Given this list of marker genes SGF29, HLX, FN1, RAB13, LAMP3, SPSB3, CD48, PACS1, NAIP, CTSZ, CTNNA1, CDKN1A, IL6R, RTN1, DDIT3, ARHGAP12, CD84, ZNF665, CTSB, IGSF6, TRAPPC6A, SYNE1, RPS27, DHRS12, RGL1 (NCBI Gene Id 23179), GRN, CTSS, SMARCD3, PLXND1, DAAM2, C1S (complement C1s), DDX60 (DExD/H-box helicase 60), PLEK, PELI2 (pellino E3 ubiquitin protein ligase family member 2), LY9, SYNGR2, MCM3AP-AS1, KLC1, HLA-F, RNF130, PIK3C2A, IFI30, TBXAS1, CLEC7A, SCML1, MARCKS, CACNB1, PECAM1, DACT1 (NCBI Gene Id 51339), ACP5, ARAP2, CROCCP2, SYNJ2BP, ZSWIM8, SGPL1, ARAP1, BCL6, FCGRT, CD68, NPC2, CD83, BTN3A1, SLC35E2A, CSF2RA, THBS2, REPIN1, OCM2, YPEL5, KAT8, FPR3 (NCBI Gene Id 2359), FCGR2B, MXI1, OFD1, DPYD, ZNF573, LIPA, HLA-C, HLA-E, SLC7A7, CCL2, BCL11B, ST3GAL5, FAM168A, N4BP2L2, IL4R, COQ8A (NCBI Gene Id 56997), FAM193B, LY75, TSC22D1, FIG4, HERC1, CD209, LRP10, TSPAN4, C1orf54, IL3RA, LIMCH1, RYK, ATP6AP1, CYBB (NCBI Gene Id 1536), GP1BA, SLC1A3, CTSA, CD302, GABARAP, SIRPA, CD81, CREG1, NEU1, ARRB1, MS4A6A, SLC8B1, ZNF266, VAMP3, TBC1D1, IFNGR2, MARCHF8, DMXL2, RHOQ, SRSF5, ABCA5, CYTH4, SLC11A2, VPS11, TSC22D3, IPCEF1, RAB20, TLR1, ZMIZ2, MINDY1, PLXNB2, POU2F1, NAGLU, CCL22, PDGFC, LYN, CKAP4, TMT1A, FSCN1, BASP1, TIMP2, TYROBP, PINK1, CCR1, R3HDM2, TGFBI, LBH, PLEKHA1, SQSTM1, FTL, ALDOAP2, ACP2, TNKS, ATP8A2, BACH2, GFOD3P, VNN2, CD86, IL1R2, MX2, CTSO, KLHL3, S100A8, MGAT1, ST14, TSPAN6, SLC2A6 (solute carrier family 2 member 6), FCER1G, TMEM176A, TYMP, PTPRE, TNFSF13, NCF1C, MILR1, CSF1R, SIGLEC5, CXCR4, SALL2, RIPK2, PLOD3, ENG, HCK, TXNIP, SLC31A2, LDLRAP1, LMBR1L, CRYL1, ZNF329, CBX6, PIP5K1C, LGALS3, PTGS1, WDR19, HLA-DPB1, KMO, ZSCAN18, MTERF4, ZNF629, here is a description of the gene set: Human Gene Set: GSE24634_TREG_VS_TCONV_POST_DAY5_IL4_CONVERSION_DN from publication Prots I, Skapenko A, Lipsky PE, Schulze-Koops H (PMID 21347372) Genes down-regulated in comparison of CD25+ T cells treated with IL4 versus CD25- T cells treated with IL4 at day 5. CD25+ regulatory T cells develop in the thymus (nTregs), but may also be generated in the periphery upon stimulation of naive CD4 T cells under appropriate conditions (iTregs). The mechanisms that regulate the generation of peripheral iTregs are largely unknown. We used microarrays to gain insights into the molecular program of extrathymic Treg development. species: Homo sapiens